Given this list of marker genes Rnf7, Ubb, Socs1, Ube2d1, Csf3, Socs3, Rps27a, Tyk2, Syk, here is a description of the gene set: species: Mus musculus Reactome Pathway: Inactivation of CSF3 (G-CSF) signaling electronically inferred by orthology from the curated human pathway part of: Signaling by CSF3 (G-CSF) This event has been computationally inferred from an event that has been demonstrated in another species.<p>The inference is based on the homology mapping from PANTHER. Briefly, reactions for which all involved PhysicalEntities (in input, output and catalyst) have a mapped orthologue/paralogue (for complexes at least 75% of components must have a mapping) are inferred to the other species.